Given this list of marker genes WNT2B, EPOR, SMARCA1, PAK6, CELA3A, AQP2, HSD11B1, CASKIN2, BAP1, BICRA, PLEKHA6, OMA1, PARP6, ZNF385A (NCBI Gene Id 25946), RAI1 (NCBI Gene Id 6600), RTL9, DNAJA1, NDST2, RASL12, PDE3A, CFAP65, EMP3, DHRS3, C6orf62, AMPH, NCDN, CSRNP3, FOXD3, KCNE5, DLL4, DLL3, RAB30, TUBB2B, IP6K3, ANKRD12, TEX35, BRINP1, AMOT (NCBI Gene Id 23340), CELF3, PRDM8, PAICS, SULT2B1, PTK7, TMF1 (TATA element modulatory factor 1), USO1, TXNDC12, NBEA, YPEL5, IRF2BPL, NADK2, PTPRS, LZTS2, TMEM100, INSR, ALDH1A1, OPCML, ABR, STAC3, B3GALNT2, ITGB1BP2, TGFB3, RNF213, PTCH2, PARP8, HIP1, NDST4, SOX12, ASB16, DMD, ZBTB18, PDGFB, XCL2, OR10J1, TP53INP2, ARHGAP45, ATRNL1, ARHGAP24 (Rho GTPase activating protein 24), SLC12A8, KCNN2, RPS6KB1, KCNMA1 (NCBI Gene Id 3778), PRICKLE1, LINC01089, RIPOR1, ERBB3, CPEB3, PADI2, DALRD3, GPR162, MAP3K13, HS3ST4, MYF5, RHOBTB2, PRKCG, NR4A3 (NCBI Gene Id 8013), IMPDH1, TFAP4, NAV3, TCF7, DES, PHF7, HOXB5, GRIK3, FOXO4, SLC26A10P, RBMS3, ENO3, TRAF4, SYTL2, PHF23, REEP6, WNT4, CITED2, EYA1, PRKCQ, GPR21, GNB3, TRAPPC3, HPCA, KLF13, GOLM2, PPAT, LNX1, ANP32A, DDIT4, SALL1, APBA1, RUSC1-AS1, MOSPD1, PDLIM4, TRAM1, TGFBR2, SIX5, LINC01138, OBSCN, SUV39H2, UNC13B, LINC00299, UBE2H (ubiquitin conjugating enzyme E2 H), VGF, IKZF2, SRGAP1, MYCLP1, QTRT2, NDUFA4L2, RASL10B, CUL7, TLNRD1, TSEN54, DOCK4, SH2D6, KCNH2, RIT1, ESR1, CAPZA3, HSD3B7 (NCBI Gene Id 80270), HMGN2, KSR2, TRIM62, IL11, BNC2, MBP, GOLPH3L, UBE2D3, BTF3P11, KCNJ2, FMO5, GRIN2D, MYO1C, CBFA2T3, CD79B, DAAM1, TMEM182, CHRNG, ARHGEF2, RUNX1 (NCBI Gene Id 861), SCN4A, UBALD2, PCBP4, GRK2, RTKN, ABHD16A, CCDC18, SOST, SLC8A3, CHRD, RASGRF2, BTG1, ATP1B4, STOML2, E2F1, ZNF710, WNT9A, ASB5, TMEM109, ABHD4, BRWD3, FZD9, CLEC4D, CCDC191, SEMA6D, ANXA8, VAMP3, CHMP4B, HJV, STIM1, CHD4, HID1, ZMIZ1, FILIP1, ABTB2, SYTL1 (synaptotagmin like 1), FBXL21P, BACH1, HDAC4, IL17B, ELF4, XPNPEP1, ID3, HOXA6, GPM6B, CMTM5, PREX2, MASP1, DMC1, WDR81, SPCS1, IGF1, PLPP7, HAPLN2, KDM2A, FOSL2, AZIN1, TPM3, ZFAND3, PGF, FAM217B, TNFRSF19, SLC25A24, SLC7A8, GGNBP2, RGS7, ARHGAP8, HBP1, CACNB2, MID2, RXRG, MAP3K3, SGMS2, RAB27A, MYL6B, ELP6, AKT2, MYBPH, ZNF398, WNT10B, PPP1R9B, VAT1, SGIP1, PABIR2, PSIP1, REEP1, ATOH8, ZRANB1, PPP1R3D, PHLDB1, PCYT1B, MAF, GASAL1, PABPC5, LRRN2, SMARCA2, MIR22HG, PPP1R17, here is a description of the gene set: Human Gene Set: AP4_Q5 Genes having at least one occurrence of the motif VDCAGCTGNN in the regions spanning 4 kb centered on their transcription starting sites. This matches the TFAP4 transcription factor binding site V$AP4_Q5 (v7.4 TRANSFAC). studied in species Homo sapiens